Given this list of marker genes Nbr1, Sqstm1, Map1lc3b, Pex5, Rps27a, Ubb, here is a description of the gene set: studied in species Mus musculus Reactome Pathway: Pexophagy electronically inferred by orthology from the curated human pathway This event has been computationally inferred from an event that has been demonstrated in another species.<p>The inference is based on the homology mapping from PANTHER. Briefly, reactions for which all involved PhysicalEntities (in input, output and catalyst) have a mapped orthologue/paralogue (for complexes at least 75% of components must have a mapping) are inferred to the other species. part of: Selective autophagy